The following is a description of a gene set: Reduced diameter of a long bone with a more pronounced reduction of the diameter of the diaphysis of the long bones. Slender long bones with narrow diaphyses Human Gene Set: HP_SLENDER_LONG_BONES_WITH_NARROW_DIAPHYSES studied in species Homo sapiens, and this is the list of marker genes: ATP6V0A2, VAC14, B3GALT6, HNRNPH1, FIG4